The following is a description of a gene set: studied in species Homo sapiens from publication Chen Y, Wang X (PMID 31504780) Genes predicted to be targets of miRBase v22 microRNA hsa-miR-4664-5p in miRDB v6.0 with MirTarget v4 prediction scores > 80 (high confidence targets). Human Gene Set: MIR4664_5P, and this is the list of marker genes: TBC1D16, CLDN7, ACLY, SOX12, ARHGEF18, TMEM150A, ACTR1A, EFHD2, FRZB, AAK1, POFUT1, KCNC4, SLC48A1, MRTFB, TRAT1, CASP9, SIGLEC14, LIMD2, HNRNPA1, ADAM8 (NCBI Gene Id 101), CPLX2, PTPRH, GCM1, RDX, PPP1R1C, FAM234A, TNFRSF6B, ZNF774, CKB, IGF2, SPRED3, ULK3, VSX2, BCL7B, ZBTB7A, SYNGAP1, VPS52, GALK2, ARRB1, SLC2A14, TMCC3, PPARGC1A, USH1G, GFAP, FAF2, WBP1L, SETD9, SUMO1, SAP30L, ZFP3, VAC14, ITPKB, IL17REL, PTPRN2, PFN1, SHISA9, MYOZ3, ZPBP2, FCER2 (Fc epsilon receptor II), SMR3B, LINC03040, RHOH, FECH, MMP16, GPRC5A, TDRD10, IGFBP5, EVI5L, SPTBN4, UQCRB, PANO1, UBE3B, EFNA2, RBMS2, MPL, ITGB4, OTOA, FOXI1, SFTPA2, CCER2, CCAR2